The following is a description of a gene set: Mouse Gene Set: GOMF_G_PROTEIN_ACTIVITY studied in species Mus musculus A molecular function regulator that cycles between active GTP-bound and inactive GDP-bound states. In its active state, binds to a variety of effector proteins to regulate cellular processes. Intrinsic GTPase activity returns the G protein to its GDP-bound state. The return to the GDP-bound state can be accelerated by the action of a GTPase-activating protein (GAP)., and this is the list of marker genes: Rab1a, Gna12, Gbp5, Rab1b, Rasl10a, Gnao1, Rap2c (NCBI Gene Id 72065), Eras, Rasl10b, Gbp2b, Rap1b, Ran, Rap2a, Rab5b, Mras, Rasl12, Sar1b, Gnai1, Rab7, Hras, Gnaq, Rala, Rac1 (NCBI Gene Id 52352), Gm12250, Rab11b (NCBI Gene Id 320652), Rhoa, Rac3, Rap1a, Rasl11a, Arl8b, Rasl11b, Rit1, Arf6, Sar1a, Rab11a, Irgm2, Nras, Rab5a, Kras, Rab10, Ralb, Gna13, Rap2b, Gbp2, Rit2, Cdc42, Rab27a (NCBI Gene Id 75673), Irgm1, Igtp, Gna11, Rab27b, Rab4a, Rerg, Gnas, Rab5c, Gnal, Rab4b